Given this list of marker genes ALG8, PPP1R10, CCDC106, GABRB1, CHMP2A, PDE7A, ZNF800, CRK, PRPF6, NRGN, CIPC, SEC14L1, STX12, POLH, CFL1, MTFR1, POU4F2, YWHAE, SPRY4, VAT1, TMEM143, SHMT2, SPOP, RILPL1, ACTR1A, MAZ, MST1, GRIN2B (glutamate ionotropic receptor NMDA type subunit 2B), CENPBD1P (CENPB DNA-binding domain containing 1, pseudogene), USP37, LSM12 (NCBI Gene Id 124801), CNOT9, MAP7D2, VAV3, PLEKHA1, MRPL45, SND1, SPINT2, ZNF248, CNTROB, PCNT, NNAT, TNKS2, UBAC2 (NCBI Gene Id 94902), CCDC12, LRP1, ARRB2, OARD1, RNF123, SMC4, FUT8, ZCWPW1, FOXO4, ATXN7L2, DNAAF1, MAGED1, AFG3L1P, TMEM50A, MECP2, EID2, TMEM255A, ARFGAP3, AIP, CCR10, PREB, FGFR1OP2, EIF1, NAA25, KCNK5, IRF2BPL, WNT5A (Wnt family member 5A), COG6, HSDL1, ARHGEF15, SAMD10, SYNGR4, MAGI1, FAM120C, INTS3, CBFB, RPRD2, PPME1, MAP4K1, U2AF2, PTGES3, JAG1, PLOD3, SNX12, DAW1, BCKDHA, ATP6V1D, BCL7A, MPDU1, TRIM28, USF2, CBX6, PAXBP1, TRIM39, SUFU, GPATCH11, ZNF428, SLC39A7, IFT80, GOLGA1, C16orf87, ASIC1, GABRB2, DDIT3 (DNA damage inducible transcript 3), ESCO1, PDXDC1, CCT3, CNTNAP1, PHAF1, PDCD2L, PHC3, TSACC, RAVER1, PABIR2, ARMC8, DNAJC3, MCRS1, BMERB1, COX7A2L, PSMA4, XRCC1, SENP7, FAM13B, ACOT13, SELENOI, SSBP4, HNRNPL, MRI1, HMMR, NAT8L, DNMT1, HOXC4, SMAD5, MRPL22, MRTFB, TDP2, SNRNP70, TUBG1, CLOCK, DNAJA1, INO80C, SRR, PHF1, PAQR4, CD320, EDEM3, HIBADH, EXOSC5, XPO5, POLA2, PCIF1, DCTN5, TMEM179, MOK, C21orf58, NFYA, HOXC6, KRCC1, CLGN, SRSF1, INTS13, PDRG1, SRSF9, BTBD3, GTF2F1, ZNF286A, ZNF287, MRPS18B, TMF1, MAP2K7, PRKN, INTS2, UXS1 (NCBI Gene Id 80146), RNF111, HTN1, RBBP8, CKS2, ZGRF1, RAB10, AFG2B (AFG2 AAA ATPase homolog B), PPP4R4, CENPO, DOK6, NDUFB8, CCNJL, EID2B, PSD (pleckstrin and Sec7 domain containing), MIB1, ADAM10, FMR1, PPP1R12A, EXOG, ABI2, SF1, PGRMC2, TECR, NEK8, E2F6, PALS1, ZNF653, CACUL1, HNRNPH1, EIF2S1, KANSL1L, CCNI, TRAPPC1 (trafficking protein particle complex subunit 1), KDM5C, ZNHIT1, SEC24C, MTRFR, KDM2A, NARF, HILPDA, CCDC97, ADO (NCBI Gene Id 84890), SRSF7, PACRG, RTF1, USO1, UQCC2, POP7, KDM4C, DISP2, RETREG3 (reticulophagy regulator family member 3), FXR2 (FMR1 autosomal homolog 2), EEF1AKMT1, NF1, TUBGCP4, FGF12, MEPCE, THAP12, MAPT, UBE2K, PTPN2, SGF29, MAGED2, EIF3K, CBY1, PALB2, PPP1R15B, RHOA, TTLL4, CDK16, BAG6, TCTA, FNBP4, ZNF638, SMAP2, POU2F1, SRRM1 (NCBI Gene Id 157635), EIF5A, NUDCD2, ZSCAN29, FUS, RAB18, SMG6, RXRB, CDK2AP2, here is a description of the gene set: Genes having at least one occurrence of the motif CGCATGCGCR in the regions spanning 4 kb centered on their transcription starting sites. This matches the NRF1 transcription factor binding site V$NRF1_Q6 (v7.4 TRANSFAC). Human Gene Set: NRF1_Q6 studied in species Homo sapiens